Given this list of marker genes Prkar1b, Zfp687, Pdzk1, Inava, Adgrl1, Zfx (zinc finger protein X-linked), S1pr5, Fam163a, Gnas, Cand2, Tmem63b, Sidt2, Eloa, Tom1l2, Atp6v0a2, Zbtb7b, Arfip1, Nav2, Zfp362, Sipa1l3, Cstpp1, Asic1, Ehd1, Crtc1, Crb2, Garre1, Tmem132b, Mecp2 (methyl CpG binding protein 2), Dedd2, Gadd45b, Lyn, Lrrc28, Zfp704, 2210016L21Rik, Bpifc, Snd1, Zc3h7b, Arid2, H2-Ob, Alx4, Kctd17 (NCBI Gene Id 97993), Agap1, Usp21, Rere, Castor2, Rfng, Cnot4, Fam163b, Ppp1r9b, Uros, Mal2, Ermap, Dusp9, Wfikkn2, Sos2, Vdac2 (voltage-dependent anion channel 2), Shisa6, Dagla, Pias2, Mnt, Col5a3, Mau2, C1qtnf6, Pacsin1, 9530068E07Rik, 5031439G07Rik, Rps6ka2, Adarb1, Jrk, Fgf18, Sdc3, Pax8, Nr4a1, Baiap2, Hnrnpab, Smco3, Cdc37l1, Limk1 (NCBI Gene Id 547389), Ccdc142, Mad1l1, Samd10, Efcab2, Grip2, Elmod1, 4921517D22Rik, Rara, Dapk1, Cacnb1 (calcium channel, voltage-dependent, beta 1 subunit), Kcnt1, Rnf5, Smarcb1, Sox10, Map1a, Stx3, Zyx, S1pr3 (NCBI Gene Id 13610), Maml3, Ap1s1, Ermp1, Fbrs, Kctd12, here is a description of the gene set: from publication Chen Y, Wang X (PMID 31504780) studied in species Mus musculus Genes predicted to be targets of miRBase v22 microRNA mmu_miR_7212_5p in miRDB v6.0 with MirTarget v4 prediction scores > 80 (high confidence targets). Mouse Gene Set: MIR_7212_5P